Given this list of marker genes Parp10, Fcer1g, Gbp7, Plin2, Ranbp2, Sat1, Selenow, Fmnl2, Isg15, Katna1, G3bp2, Nmi, Spop, Aida, Ccdc25 (NCBI Gene Id 67179), Tpx2, Herc6, Cd47, Ifi209, Rcc1, Slfn1 (schlafen 1), Serpina3f, Aldh1b1, Phf11a, Tmem229b, Mndal, Jaml, Procr, Apod, Acod1, Eif2ak2, Ifit3, Hat1, Ifi204, Rin2, Stat2, Sap30, Nkiras2, Ifih1, Txn1, Oas3, Psmb9, Dnaja2, Plekhf2, Hspa5, Slfn5, Irf1, Cd69, Isg20, Kat2b, Cnp, Creld2, Ccl9, Cited2, Nt5c3, Lgals3, Prkx, Casp1, Serpina3g, Tap1, Rnf19b, Psmb10, Parp14, Il10ra, AI837181, Fcgr4, Ccl12, Arid5a, Fndc3a, Nono, Sp110, Daxx, Stx11, Rock1, Gch1, Tnfsf10, Fcgr3, Zup1, Ifi211, Ifi213, Ifi205, Dek, Scimp, Rigi, Phf11b, Rap2c, Trafd1, Spi1, Gbp8, Psme1, Tpm4, Nampt, Etnk1, Rnf114, H2-T23 (NCBI Gene Id 15040), Tspo, 9930111J21Rik2, Trim30a, Ifi44, Sp100, Lgals9, Uaca, Samhd1, Ifit3b, Mospd2, Gbp9, Stat3, Clec10a, Bbx, Cd40, Wars1, Ppa1, Cndp2, Ly86, Tcstv4, Mthfr, Oasl1, Fam241a, Carmil1, Socs1, Klrk1, Tor1aip1, Oas2 (NCBI Gene Id 246728), Cxcl9, Pml, Slfn2, Lap3, Ifi207, Ms4a6c, Samd9l, Trim30c, Rtp4, Irgm1, Gadd45b, Spred1, Stat1, Ifi35, Xaf1, Shisa5, Cxcl10, Jpt1, Smchd1, H3f3b, Ifi203, Arf4, Calhm6, Rnf213, Psmb8, Evi2a, Il15ra, Snx2, Ms4a6b, Ccl8, Rbms1, Prpf38a, Ms4a4c, Phf11d, Ube2l6, Sct, Ccl7, Irf7, Dck, Mlkl, Chmp4b, Slfn8 (schlafen 8), Parp3, Iigp1, Irf8, Ccl2, Ncoa7, Tor1aip2, Anxa4, Tor3a, Ppp1r2, Rsad2, Pnpt1, Cldnd1, Sp140 (Sp140 nuclear body protein), Ccdc71l, Ifit1, Cmpk2, Inpp5b, Ifit2, Cd274, Ogfr, Calm1, Ube2d3, Xdh, Gnb4, Rab8b, Marchf5, Map2k1, Il27, Ilrun, Ifi208, Sco1, Dnaja1, H2-T22, Pnp, Pi4k2a, Tut4, Atad1 (NCBI Gene Id 67979), Max, Znfx1, Rfc2, Csrp1, Gbp5, Oasl2 (NCBI Gene Id 23962), Arl6ip5, Trim56, Trim25, Pttg1, Epsti1, Zyx, Cdkn1a, Mx1, Ifi47 (NCBI Gene Id 15953), Gbp3, Casp4, Dhx58, Ifitm3, Ly6a, Cpne3, Parp12, Ifi206, Usp25, Hck, Tent4a, Ptk2b, Usp18, Gbp4, Sertad1, Dbnl, Il15, Ifi214, Igtp, Mov10, Ifit1bl1, Tapbp, Tpst1, Mitd1, Cebpb, Trim30d, Mxd1, Parp11, Dtx3l, Bst2, Ptpn1, C1qb, Golga3, Rfc3, Gbp2, Parp9 (NCBI Gene Id 80285), Clic4, Fcgr1, Themis2, Zbp1, Gbp2b, Irgm2, here is a description of the gene set: from publication Cui A, Huang T, Li S, Ma A, Pérez JL, Sander C, Keskin DB, Wu CJ, Fraenkel E, Hacohen N (PMID 38057668) species: Mus musculus Mouse Gene Set: CUI_MACROPHAGE_IFNA1_RESPONSE_UP Cytokines mediate cell-cell communication in the immune system and represent important therapeutic targets. A myriad of studies have highlighted their central role in immune function, yet we lack a global view of the cellular responses of each immune cell type to each cytokine. To address this gap, the authors created the Immune Dictionary, a compendium of single-cell transcriptomic profiles of more than 17 immune cell types in response to each of 86 cytokines (>1,400 cytokine-cell type combinations) in mouse lymph nodes in vivo. A cytokine-centric view of the dictionary revealed that most cytokines induce highly cell-type-specific responses. For example, the inflammatory cytokine interleukin-1β induces distinct gene programmes in almost every cell type. A cell-type-centric view of the dictionary identified more than 66 cytokine-driven cellular polarization states across immune cell types, including previously uncharacterized states such as an interleukin-18-induced polyfunctional natural killer cell state. Genes positively differentially expressed in cell type: Macrophage upon treatment with cytokine: IFN-α1 in mouse lymph nodes in vivo.